Given this list of marker genes Sirt1, Pgr, Edn2, Adamts1, Mmp19, Afp, Nos2, Pde4d, Foxo3, Mmp2, Lep, Agt, Nrip1 (NCBI Gene Id 77882), Oas1d, Pla2g4a, Nos3, here is a description of the gene set: species: Mus musculus The process leading to the rupture of the follicle, releasing the centrally located oocyte into the oviduct. An example of this is found in Mus musculus. Mouse Gene Set: GOBP_OVULATION_FROM_OVARIAN_FOLLICLE